Given this list of marker genes IL7R, CD3E, CD247, RAG2, RAG1, DCLRE1C, PGM3, PNP, IL2RG, CD3D, here is a description of the gene set: Any abnormality in the proportion of CD3-positive T cells relative to the total number of T cells. Decreased CD3+ T cell proportion studied in species Homo sapiens Human Gene Set: HP_DECREASED_CD3_T_CELL_PROPORTION